The following is a description of a gene set: Mouse Gene Set: REACTOME_GABA_B_RECEPTOR_ACTIVATION GABA B receptor activation studied in species Mus musculus, and this is the list of marker genes: Gnb4, Adcy2, Kcnj16, Gng10, Gng11, Gng12, Adcy7, Gng2, Kcnj12, Adcy5, Kcnj10, Kcnj15, Gnal, Kcnj9, Gabbr2, Gng8, Kcnj4, Gnai1, Gnb3, Gnai3, Adcy9, Gng7, Gnb2, Gnat3, Kcnj6, Gngt1, Gnai2, Adcy3, Adcy8, Gng4, Gng13, Kcnj5, Adcy1, Kcnj2, Adcy6, Kcnj3, Adcy4, Gabbr1, Gnb5, Gngt2, Gng5, Gnb1, Gng3